The following is a description of a gene set: species: Homo sapiens Human Gene Set: BAHD1_TARGET_GENES Genes containing one or more binding sites for (BAHD1) in their promoter regions (TSS -1000,+100 bp) as identified by GTRD version 20.06 ChIP-seq harmonization. from publication Yevshin I, Sharipov R, Kolmykov S, Kondrakhin Y, Kolpakov F (PMID 30445619), and this is the list of marker genes: RNF130, TOMM20P4, MIR7-3HG, RPL7L1P19, H2BP8, MTND2P29, TMEM233, MIR466, CRAT37, LINC02397, ENO1, PENK, LINC02133, TUBGCP5, RN7SL474P, ZNF75A, RPL35AP30, ZNF404, ENO1-AS1, PIP5K1C, ZNF573, GARS1-DT, OTOA, ZNF227, SERPINB13, PENK-AS1, RPL23AP55, CYSLTR2, GNPTG, MIR7-3, AKR1B1P1, LINC01717, SNAP25-AS1, ENSG00000207147, ARGFXP1 (arginine-fifty homeobox pseudogene 1), RHPN2, PRKAG2, LINC01600, SNAP91, CHFR, TSR3